The following is a description of a gene set: In this study, an extensive analysis was conducted to define meta-programs (MPs) capturing intra-tumor heterogeneity across a spectrum of tumor types. The approach utilized non-negative matrix factorization (NMF) to analyze each cell type separately within individual tumor samples. This involved the analysis of malignant cells, macrophages, fibroblasts, endothelial cells, epithelial cells, T-cells, and B-cells. NMF was executed with varying parameter values (K=4, 5, 6, 7, 8, 9), thereby generating 39 programs for each cell type per sample. Each NMF program was summarized by the top genes based on NMF coefficients.\nRobust MPs were then delineated for each cell type using a set of stringent criteria, including recurrence within the same tumor, similarity to programs in other tumors, and non-redundancy within a tumor. Subsequently, these robust NMF programs were clustered (per cell type) based on Jaccard similarity, leading to the identification of MPs associated with each cell type.\nTo enhance the quality of the MPs, a refinement steps were undertaken, involving the removal of MPs suspected of reflecting low-quality data (with an overrepresentation of ribosomal proteins or mitochondrial-encoded genes), single-study inclusion, or similarity to miss-annotated cell types. from publication Gavish A, Tyler M, Greenwald AC, Hoefflin R, Simkin D, Tschernichovsky R, Galili Darnell N, Somech E, Barbolin C, Antman T, Kovarsky D, Barrett T, Gonzalez Castro LN, Halder D, Chanoch-Myers R, Laffy J, Mints M, Wider A, Tal R, Spitzer A, Hara T, Raitses-Gurevich M, Stossel C, Golan T, Tirosh A, Suvà ML, Puram SV, Tirosh I (PMID 37258682) studied in species Homo sapiens Genes upregulated in subsets of cells of a given type within various tumors Human Gene Set: GAVISH_3CA_MALIGNANT_METAPROGRAM_34_PLATELET_ACTIVATION, and this is the list of marker genes: FCER1G, CD9, RGS18, ITGA2B, CCND3, HBD, PPIF, BIN2, MPIG6B, C2orf88, LAT, RAP1B, DAD1, PF4, LIMS1 (NCBI Gene Id 3987), CMTM5, GP9, PLEK, TMSB4X, ACTN1, TPM1, PRKAR2B, MGLL, FERMT3, CAVIN2, LGALS1, FYB1, PBX1, FLI1, CKB, GUCY1B1, STOM, CD36, VCL, NRGN, PDLIM1, SLC44A1, TGFB1, GATA2, MAX, PIM1, RAB27B, GSN, FCER1A, CLU, MMRN1, VASP, TPM4, PKM